Given this list of marker genes CCNA1, WEE1, CCNB1, CCNB2, PKMYT1, CCNA2, CDK1, here is a description of the gene set: G2/M DNA replication checkpoint species: Homo sapiens Human Gene Set: REACTOME_G2_M_DNA_REPLICATION_CHECKPOINT